The following is a description of a gene set: Genes up-regulated in HB2 cells (mammary epithelium) upon expression of KDM5B off an adenoviral vector. Human Gene Set: SCIBETTA_KDM5B_TARGETS_UP The PLU-1/JARID1B nuclear protein, which is upregulated in breast cancers, belongs to the ARID family of DNA binding proteins and has strong transcriptional repression activity. To identify the target genes regulated by PLU-1/JARID1B, we overexpressed or silenced the human PLU-1/JARID1B gene in human mammary epithelial cells by using adenovirus and RNA interference systems, respectively, and then applied microarray analysis to identify candidate genes. A total of genes showed inversely correlated differential expression in the two systems. Most of the candidate genes were downregulated by the overexpression of PLU-1/JARID1B, including the MT genes, the tumor suppressor gene BRCA1, and genes involved in the regulation of the M phase of the mitotic cell cycle. Chromatin immunoprecipitation assays confirmed that the metallothionein 1H (MT1H), -1F, and -1X genes are direct transcriptional targets of PLU-1/JARID1B in vivo. Furthermore, the level of trimethyl H3K4 of the MT1H promoter was increased following silencing of PLU-1/JARID1B. Both the PLU-1/JARID1B protein and the ARID domain selectively bound CG-rich DNA. The GCACA/C motif, which is abundant in metallothionein promoters, was identified as a consensus binding sequence of the PLU-1/JARID1B ARID domain. As expected from the microarray data, cells overexpressing PLU-1/JARID1B have an impaired G(2)/M checkpoint. Our study provides insight into the molecular function of the breast cancer-associated transcriptional repressor PLU-1/JARID1B. studied in species Homo sapiens from publication Scibetta AG, Santangelo S, Coleman J, Hall D, Chaplin T, Copier J, Catchpole S, Burchell J, Taylor-Papadimitriou J (PMID 17709396), and this is the list of marker genes: MPC1, KLHDC10, CD2BP2, RNASET2, NDE1, EHD1, DNAL4, CLCF1, MIA3 (NCBI Gene Id 440718), POLB, CDIPT, SAT1, OSER1, GADD45A (NCBI Gene Id 1647), MAPK8IP3, RNF40, SMOX, DDIT3, BBS9